Given this list of marker genes Pafah1b1, Prag1, Jam3, Stk26, Psd3, Nf1, Cped1, Spopl, Cdk13, Csnk1g3, Vps54, Plxna1, Fnip1, Iigp1, Fbxo45, Arhgef6, Frs2, Tal1, Suz12, Clock, Otx2, Igf2bp3, Dpysl3, Pcdh7, Derl2, Mgrn1, Ltn1, Zdhhc17, Tsc1, AU041133, Ezh2, Tgfbr1, Fbn1, Gata6, Stk24, Ccdc6, Gna13, Htr2c, Ube2h, Mnat1, Pik3ca, Bcl2 (B cell leukemia/lymphoma 2), Mtdh, Ilk, Bcl9, Rpl5, Gab2, Tmem129, Ankra2, Adamts6, Rmdn3, Eeig2, Gm6377, Phip, Atxn7, Brd1, Rasa2, Zbtb10, here is a description of the gene set: Mouse Gene Set: MIR_3101_5P from publication Chen Y, Wang X (PMID 31504780) Genes predicted to be targets of miRBase v22 microRNA mmu_miR_3101_5p in miRDB v6.0 with MirTarget v4 prediction scores > 80 (high confidence targets). studied in species Mus musculus